The following is a description of a gene set: Any process that results in a change in state or activity of a cell or an organism (in terms of movement, secretion, enzyme production, gene expression, etc.) as a result of an antibiotic stimulus. An antibiotic is a chemical substance produced by a microorganism which has the capacity to inhibit the growth of or to kill other microorganisms. species: Homo sapiens Human Gene Set: GOBP_RESPONSE_TO_ANTIBIOTIC, and this is the list of marker genes: SKIL, ETS1, KDM1A, ZC3H8 (NCBI Gene Id 84524), ALPL, HPSE, SRD5A1, CDKN1B, EHMT1, CYB5R4, SLC9A1, KDM6B, RPL23 (NCBI Gene Id 9349), MDM2, ABCB1, JAK1, CIITA, KAT7, PLA2G4F, JAK2, GRIA1, HYAL2, SLC1A3 (NCBI Gene Id 6507), MEF2C, HYAL1, HYAL3, TP53, CRIP1, EZH2, HSP90AA1, ENDOG, PLA2G4A, PPP2CB, VPS54, KDM5B (lysine demethylase 5B), ID1, RSRC1